The following is a description of a gene set: Human Gene Set: GOMF_PHOSPHATE_TRANSMEMBRANE_TRANSPORTER_ACTIVITY Enables the transfer of phosphate ions from one side of a membrane to the other, up its concentration gradient. The transporter binds the solute and undergoes a series of conformational changes. Transport works equally well in either direction and is driven by a chemiosmotic source of energy. Secondary active transporters include symporters and antiporters. studied in species Homo sapiens, and this is the list of marker genes: SLC25A3, ANKH, SLC25A25, SLC34A2, SLC17A4 (solute carrier family 17 member 4), SLC25A24, ADAMTS8, SLC17A3, SLC34A1, SLC17A1, SLC34A3, SLC17A6, SLC20A1, SLC17A2, SLC37A2, SLC37A3, SLC17A7, SLC37A4, SLC25A23, SLC20A2, UCP2, SLC17A8, SLC37A1, XPR1